The following is a description of a gene set: Human Gene Set: chr5q21 studied in species Homo sapiens, and this is the list of marker genes: PJA2, MIR548P, KRT18P42 (NCBI Gene Id 391819), RNU1-140P, PGAM5P1, CRLF3P2, GUSBP8, FER, MTND6P22, PDZPH1P, ENSG00000283462, SLCO6A1, FBXL17, LINC01950, OR7H2P, EIF3KP1, FAM174A, MTCO2P22, MTCO3P22, RNU6-334P, RN7SL255P, RNU6-47P, LSM2P2, LINC02113, GUSBP7, RN7SL802P (RNA, 7SL, cytoplasmic 802, pseudogene), MTND3P19, ENSG00000251574, RN7SL782P, ST8SIA4, RNA5SP189, CHD1, NIHCOLE, MTCO1P22, GJA1P1, PPIP5K2, LINC01848, MAN2A1-DT, MTND5P10 (MT-ND5 pseudogene 10), GIN1, RN7SKP68, RNA5SP188, EFNA5, LINC02115, SLCO4C1, LINC00491, MTND4LP5, RNU6-1119P, MTATP6P2, RAB9BP1, MTCYBP22, MTND4P35, LINC01023, ENSG00000296200, ENSG00000248203, RN7SKP122, LINC00492 (long intergenic non-protein coding RNA 492), PAM (peptidylglycine alpha-amidating monooxygenase), EEF1A1P20, FAM174A-DT, CHD1-DT, ENSG00000249787, GUSBP19, RACK1P1, ENSG00000249476, NUDT12, MAN2A1, MACIR (macrophage immunometabolism regulator), RN7SKP230, PSMC1P5, RN7SKP62, ENSG00000305324 (NCBI Gene Id 105379119)